Given this list of marker genes RABGAP1, NR2C2, EDNRB, RGMB, ADAM9, UNC80, SYTL4, CDCA7, SYDE1, ARL4C, HIF1AN, FZD3, TXNIP, CPEB1, GUCA1C, MYLK, E2F5, TMEM64, RASGEF1A, LAMA3, KIF3B, TNRC18 (NCBI Gene Id 84629), ANKRD13C, CCNJ, DPYSL5, CYBRD1, ZNRF3, ZKSCAN1, TMEM86A, TNKS2, SLAIN2, COG5, IRF2BP2, E2F7, NR4A3, MED12L, SHCBP1, ATF6B, LRP8, CREB5, ZC3H13, BLCAP, SUV39H1 (SUV39H1 histone lysine methyltransferase), PTPN21, YOD1, C2orf69, PHKA1, NPAS3, MIXL1, ROCK2 (Rho associated coiled-coil containing protein kinase 2), NFIA, PHF12, TGFBR2, RSBN1, OLFM3, TSEN34, DNAI7, MICA, HDAC4, TIAM1, ZNF827, LRP2, LEFTY1 (left-right determination factor 1), GPM6A, ITPRIPL2, UBE2Q2 (NCBI Gene Id 92912), RBL1, MBNL3 (NCBI Gene Id 55796), CORO2B, LCOR, USP16, SKIDA1, ZNF532, AAK1, PARP8, DPP8, PPARA, TMEM170B, ASAP1, RUBCN, MCL1, MIGA2, ZNF800, CNOT6, KPNA2, SDC1, DDHD1, GPCPD1, OXR1, PDE8A, SS18L1, HECTD2, ISM2, MYRF, RYR2, GALNT3, TIPARP, SLC40A1, KAT2B, SMARCC2, REST, CLIP4, SSX2IP, PKHD1, PPP6C, ZBTB7A, MSL1 (MSL complex subunit 1), CYB5D2, ST7L, ASF1B, CROT, CFL2, RORA, GUCY1A1, HP1BP3, NUFIP2, UNKL, JPT1 (NCBI Gene Id 51155), FGD4, PRDM8, MARCHF11, CMTR2, SPTLC2, TSHZ3, MKNK2, ELAVL2, RELA, EIF3M, ANKRD52, LAMP5, RNF216, LEFTY2, UBE2J1, PAK5, LHX6, PTPRD, NFIB (nuclear factor I B), BARX2, C6orf15, BTG1, SLC15A2, KIF26B, PDE4D (phosphodiesterase 4D), NHSL3, PLAG1, ARID4A, LMO3, DRD1, IRF2, GLIS3, FGD5, LATS2, TAPT1, PLAGL2, PSD3, MPC1, RAD18, TCAIM, SNRK, ARHGEF17, FAT4, CELF2, SERF1A, CYP20A1, JAZF1, RAB11FIP5, TAGAP, ZBTB33, ARHGEF10, SAMD12, SRCIN1, USP46, RGL1, PRRG1, AGO1, R3HDM1, ZRANB1, DYNC1LI2 (NCBI Gene Id 1783), KMT5B, ZBTB41, MFAP5, ARID4B, TMEM123, ZNF385A, FYCO1, ITGB8, TMUB2, SNX8, INO80D, ANKRD17, DCAF6, MTUS1, MYCN, DCUN1D4, MAP3K14, RAB11FIP1, FSTL5, HAUS8, BCL6, SLAIN1, RRAGD, BCAP29, RASSF2, FZD6, RAB5C, BCL11A, ARID5B, H2AJ, QRSL1, TBC1D2, SUZ12, FNDC3A, GNPDA2, MIER3, GPR6, PFKP (phosphofructokinase, platelet), ANO6, EZH1, ZNF75A, ELK4 (ETS transcription factor ELK4), E2F2, TBC1D8B, TFAP4, WDR37, GPC6, TRIM36, HIPK3, EXOC5, MAN1A1, DENND5B, ZFX, SERF1B, EPHA5 (EPH receptor A5), RAB11A, DUSP2, CXCL1, TRAPPC14, LYST, ARMC8, VDR, ST3GAL1, ASF1A, ZNF362, ATAD2, CYBB, MAPK9, TRIP11, NFYA, SPOP, TET1, C2CD2, FMR1, ABHD3, TWF1 (twinfilin actin binding protein 1), CYP26B1 (NCBI Gene Id 56603), ZBTB5, ARHGAP30, SLC33A1, ALDH1L2, PDIK1L, ADAT2, SON, TANC1, RNF6, MCC, UBE2B, FAM168B, TMTC2, GRM5, KDM1B, RSF1, FRMD4A, SYNC (NCBI Gene Id 81493), ERCC4, APP, ZBTB11, PIGM, PHACTR4, MARCHF5 (NCBI Gene Id 54708), TET2, RB1CC1, POLQ, DNAJC27, SUCO, CAPRIN2, DMTF1, CREBRF, TET3 (tet methylcytosine dioxygenase 3), RUNX2, RBBP9, VLDLR, RPS6KA3, REEP3, CDC23, PRDM4, RAB22A, DCUN1D1, CUX2, SETBP1, PAK2, ZFYVE26, CUX1, TMEM100, RELL1, ZNF367, GDF11, PHF14, RTN1 (NCBI Gene Id 8108), CCSAP, LHX8, TNFAIP1, KREMEN1, SLC22A23, SPRED1, USP24, HOOK3, IKZF2, RFX3, MTF1, SMNDC1, GLCE, AMER2, PTGDR, SLC24A2, HS2ST1, TP53INP1, PKD2, PAF1, MAP3K2, MBD2, here is a description of the gene set: studied in species Homo sapiens Human Gene Set: MIR520D_3P from publication Chen Y, Wang X (PMID 31504780) Genes predicted to be targets of miRBase v22 microRNA hsa-miR-520d-3p in miRDB v6.0 with MirTarget v4 prediction scores > 80 (high confidence targets).